Given this list of marker genes Slc10a2, Alb, Slc51b, Ncoa2, Slc27a5, Slco1b2, Slc51a, Baat, Slc10a1, Nr1h4, Abcb11, Rxra (retinoid X receptor alpha), Slco1a4, Abcc3, Fabp6, Ncoa1, Stard5, here is a description of the gene set: Mouse Gene Set: REACTOME_RECYCLING_OF_BILE_ACIDS_AND_SALTS Recycling of bile acids and salts studied in species Mus musculus